The following is a description of a gene set: studied in species Mus musculus Catalysis of the reaction: acetyl-CoA + histone H4 = CoA + acetyl-histone H4. Mouse Gene Set: GOMF_HISTONE_H4_ACETYLTRANSFERASE_ACTIVITY, and this is the list of marker genes: Ep300, Crebbp (CREB binding protein), Mcm3ap, Brpf3 (bromodomain and PHD finger containing, 3), Naa50, Ncoa3, Kat5 (NCBI Gene Id 81601), Naa60, Nat8f3 (NCBI Gene Id 93674), Nat8f7, Ncoa1, Ing4, Brd1, Taf1, Kat2a, Kat8, Hat1, Cdyl, Jade1, Clock, Kat2b, Kat6a, Brca2, Kat7, Brpf1, Gtf2b, Kat6b, Naa40, Ing3, Gtf3c4, Jade2, Meaf6, Atf2, Usp22